The following is a description of a gene set: Genes having at least one occurrence of the motif NMGATANSG in the regions spanning 4 kb centered on their transcription starting sites. This matches the LMO2 transcription factor binding site V$LMO2COM_02 (v7.4 TRANSFAC). Human Gene Set: LMO2COM_02 studied in species Homo sapiens, and this is the list of marker genes: EN1, TPI1P2, NR5A2, GUCA2A, LIFR, PPARGC1A, RBPMS, PLXNB3, IGFBP5, KCNK3, ANGPT1, CAMK1D, GAS2L1, MBNL1, SCHIP1, RUNX1 (RUNX family transcription factor 1), MYH10, TRPM3, EPB42 (NCBI Gene Id 2038), ADCY6 (NCBI Gene Id 23320), CDH5, SYT7, CALM2, CNOT3, CSF2, BABAM1, C22orf31, HOXC11, RAB24, GSPT2, MTCH2, KCNJ15, SFTPC, TSHB, CCNE1, SUSD1, RBFOX1, HTR7, MAML3, SPTB, PRR18, PPT2, WBP4, MFF, CACNA2D3, HAGHL, CTCF, TTBK2, CMAS, FEV, CAST, PTP4A1, SGIP1, PPOX, BNC2, GPLD1, LHX6, UNC13D, INHA (NCBI Gene Id 3623), NR4A1, PRDM1, STAG3L4, PHOX2B, HOXA10, RUNX1T1, NAA38, SIAH3, FYN, MACO1, TBX19, STARD13, TBX5, SP3, MAP4K5, CACNA1F, AMFR, GADD45G, AMHR2, SLC13A1, FOXP2, MYH4, ECHDC2, PEX5, BMP6, PLEKHG6, ILRUN, BCL6, CAVIN2, ADAMTSL1, PCDH9, BAMBI, ZZEF1, PILRB, SLC41A1, MOGAT2, PI4K2A, CYB5D1, GSE1, ISYNA1, LMO2, FBXL18, SEMA7A, DIO2, HNF1A, SFRP5, RAB43, OTOP2, NMNAT2, TNPO3, VPS18, UROD, TACC1, SALL1, WNT11, RAP1B, NCDN, KIRREL2, CPEB4, TOB1, ITGB1BP2, PRR34 (NCBI Gene Id 55267), S1PR2, AGPAT4, CREB5, SAMD7, PRDM15, ENOX1, RAB3C (RAB3C, member RAS oncogene family), CAPN1, CLU, SPRY4, GRIN2B (glutamate ionotropic receptor NMDA type subunit 2B), MYL7, DMTN, GATA1, LRRC4, XPO6, FAM106A, MITF, SLC8A3, VSTM2A, TRIM15, ISL1 (ISL LIM homeobox 1), ELAVL4, BIN1, USH1G, SIX1, TNK2, GATA6, PIP5K1B, AQP2, PPM1E, CRLS1, MYO18A, ARHGEF10L, NECTIN2, PNLIPRP1, DAB2, SH2B3, CYB5D2, FOXO4, SYN1, ABCG5, RFLNB, SKIDA1, PKN1, LCAT, HNRNPL (NCBI Gene Id 91538), UBE2B, DLX3, SYNJ1, ZFPM1, CD34, ID2, ADM, PAX2, TRIM10, LINC00670, PKIA, AP1B1, PMS2P5, MASP1, LYL1, TPH2, HBZ, FOSL2, TMEM88, ZBTB7B, NDRG2, SH3TC2, DOK2, ABL1, PRELID1, MCTS1, KRT72, SPINT1, ATP6V0A1, ZNF219, TFR2, ABCA12, NAA80, RBP3, ELF1, TNFSF13B, NR3C1, ESPNL, GRID2, KLHDC8B, HYAL3, HPSE2, ING4, FOXA1, ACVRL1, NRP2, ART4, PGGT1B, ICAM2, FKBP2, PLA2G1B, MAP4K3, NOB1, SLC4A1, PITX2, CCSER2, CCL27, HINT1, TMEM196, SLC26A9, FGF16, SCUBE3, NUFIP2, NTF4, ANKS1B, STAU1, GFRA3, KRT80, RNF112, SOX5, ABCG8, PPP2R3A, IL34, SETD2, FZD4, ASIC2